The following is a description of a gene set: from publication Chen Y, Wang X (PMID 31504780) Genes predicted to be targets of miRBase v22 microRNA mmu_miR_20a_3p in miRDB v6.0 with MirTarget v4 prediction scores > 80 (high confidence targets). studied in species Mus musculus Mouse Gene Set: MIR_20A_3P, and this is the list of marker genes: Atrnl1, Rbpj, Prss59, Inka2, Atrn, Zcchc14, Phip, Ccdc121rt2, Cblb, Cdh3, Ctdspl2, Ctps1, Erg, Galnt3, Dr1, Mkrn3, Cnnm1, Slc35g2, Dynlt3, Mllt3, Spry1, Slain2, Btaf1, Chn2, Tln1, Ddx17, Mpeg1, Lamp2, Spink5, Arf6, Ms4a6b, Grb10, Adam10, Pramel3a, Dnajc7, Rb1cc1, Socs5, Zfp26, Brd10, Pramel3e, Hspa12a, Fbn2, Nfe2l2, Ctcf, Hycc2, Clcn5 (chloride channel, voltage-sensitive 5), Bcas2, Arhgef10, Dcaf12, Ppp4r1, Gucy1b2, Ppm1e, Sorcs1, Cadm2, Gpatch2, Nectin3, Dyrk1a, Bahd1, Rab6a, Cntnap1, Rnf6, Zfp72, Zeb2, Ehmt1, Pramel3b, Atcay, Kazn, Synrg, Ezh2, Meox2, Ccdc121rt3, Hmgn2, Fgf7, Rbm39, Pnrc2, Zfp74, Tspan2, Usp27x, Slc41a2, Trim52, Rnf114 (NCBI Gene Id 99401), Htra4, Slc38a2, Cpeb2, Bmpr2 (bone morphogenetic protein receptor type 2), Smim10l1, Lck, Dsg1c, Spin4, Cpeb3, Rnf214, Vps37b, Cttnbp2nl, Ago2, Zfp820, Ptprr, Tdrd7, Gng2, Satb1, Fuca2, Tenm4, Lpin2, Pcf11, Acvr2b, Wapl, Slc9a7, Rnf19a, Npas3, Cxxc4, Ablim1, Mdc1, Tbc1d5, Pramel3c, Aicda (activation-induced cytidine deaminase), Cacnb4, G2e3, Zfp410, Star, Dsg1b, Setd7